Given this list of marker genes Exoc3, Tnfaip2, Ralb, Ralgapb, Ralgapa2, Exoc3l, Exoc3l4, Exoc3l2, here is a description of the gene set: Mouse Gene Set: GOBP_EXOCYST_LOCALIZATION studied in species Mus musculus Any process in which an exocyst is transported to, or maintained in, a specific location. An exocyst is a protein complex peripherally associated with the plasma membrane that determines where vesicles dock and fuse.